Given this list of marker genes PIP4K2C, DNAAF2, ARHGAP35, G3BP2, RAB5A, RSPH1, TBC1D5, STYXL1, KNTC1, EFNB1, DNAH8, INCENP, LSM4, SDC4, VPS37A, UBAP2L, MYH6, SMC3, CDC14C, DNAL1, EHD2, NDUFAF2, TBC1D9B, LMOD2, RPGRIP1L, SNX10, CBLN1, C2CD3, SMC1A, TUBB, ONECUT2, TBC1D12, MEF2A, CRK, CEP126, AP1B1, RAB11FIP3, CEP72, KIF9, TEKT5, SPAG1, VPS4A, RPS15, NOA1, EIF1AX, TPX2, HAP1, SNX4, FLNA, MAPT, SEPTIN7, TBC1D1, CENPC, TRAF6, TUBGCP5, SPEF2 (NCBI Gene Id 80192), B9D1, RAB8B, EIF5B, TCIRG1, VANGL2, DYNC2I2, RAB20, CHMP1B, MYBPC3, BSCL2 (NCBI Gene Id 84753), BBOF1, METTL17, AMBRA1, TMEM216, G3BP1, PWP2, NOP2, TMPRSS12, BCCIP (NCBI Gene Id 56647), STX18, MYO7A, CFAP263, CEP290, UBQLN1, PATL1, KIF23, SPACA9, RCC1L, STAM, MAP4, DDX6 (DEAD-box helicase 6), NME8, CETN1, C1QL2, KIF24, STAM2, NME5, TUBGCP4, CCDC146, LIMK2, GRB7, MTG2, DNMBP, CFAP20, PROX1, ARHGEF5, IFT74, VPS37B, CCDC57, UBXN10, SPAG17, MAP1LC3B, RPSA2, PIKFYVE, CENPW, PLK2, DYNC2I1 (NCBI Gene Id 55112), MYOM3, MRPS2, GBF1, HPS5 (HPS5 biogenesis of lysosomal organelles complex 2 subunit 2), BMP10, CEP44, AUP1, RAB3GAP2, ERAL1, GSN, CFAP65, GABARAP, EHD1, TTLL5 (tubulin tyrosine ligase like 5), POC1B, HYLS1, HGS, IFT43, CFAP74, SMAD4, PPP2R1B, SEC22B (SEC22 homolog B, vesicle trafficking protein), CHMP4BP1, NEGR1, TEKT2, CEP350, UBQLN2 (ubiquilin 2), NUDCD3, IFT140, EVI5, B9D2, DYNC2LI1, CIBAR2, CHMP4A, ATG9B, TMOD2, TBC1D7, PTK2B, TTLL8, DCDC2, MARCHF7, NSFL1C (NSFL1 cofactor), RELN, AVIL, RAB39A (NCBI Gene Id 54734), MYPN, TBC1D21, DAW1, RPF2, MOSPD2, SNX18, B3GLCT, TBC1D17, SPAG6, TMEM237, AAAS, MACIR, RNF4, CFAP57, FUS (FUS RNA binding protein), CCDC13, AP3B1, DNAH17, NUP62, FBXO24, KIF15, MOAP1, CRIPT, NGRN, MTERF4, CDK10, PTPN23, IQCG, CENPX, MPV17L2, DNAI1, SYNPO2L (NCBI Gene Id 79933), TTLL3, AP1S2, MICALL1, DTNBP1, MKKS, C10orf90, TBC1D2, CHN2, VMP1, GABARAPL1, KAT2A, CLN3, CCP110 (NCBI Gene Id 9738), CCNO, EHD4, DYNC1H1, ANKRD23, C1QL3, TNNT3, SDCBP, SPG11 (NCBI Gene Id 80208), ABCC4, ANKRD1, GRID2 (NCBI Gene Id 2895), FAM161A, VTA1, NPM1, GALNT11, CIBAR1, AGFG1, CNOT7, AP1M1, LRRK2, NEK7, CFAP298, CSRP3, SKA1, PSEN1, DCTN1, TIA1 (NCBI Gene Id 7072), TNRC6A, CCDC39, RILPL2, VIPAS39, YTHDF2, ALKBH5, DNAJB13, ACTR2, ATG5, LRFN1, ELMOD1, CENPE, CAPN3, TPGS1, BECN2, DLGAP5, LIMD1, PDGFRB, WWTR1, MAPRE1, KIAA0319L, DZIP1, GMNC, VPS11, MNS1, HAUS7, CCDC159, TXNDC15, CFAP46, CPLANE1, TBC1D24, CENPT, EML3, MAP1LC3B2, CBY1, CEP162, MYBPC1, ARL3, CFAP157, NUMA1, POC5, NBDY, LCP1, SKA2, LRRC46, ACTG1, TBC1D22A, EIF5, GARIN1A, RACGAP1, BIRC5, MZT1, SRPX, MAP10, ARL6, CCDC61, ODAD1 (NCBI Gene Id 93233), CEP63, DNAH1, CORO1A (coronin 1A), DCX, AP1S1, CFAP184, ATG4C, RC3H1, CFAP70, KIFC1, MISP, ONECUT1, RPS5, USP9X, RAB3GAP1, BNIP3, ATAT1, ATXN10, TMEM17, CFAP119, INPP5E, PATL2, WDR35, IFT22, DNAAF1, EVI5L, EDC3, SEPTIN9, ELMOD3, PGM5, FBF1 (Fas binding factor 1), GORAB, GAS8, MYH10, STAG1, BBS7, OCRL, OGFOD1, IQUB, AP5Z1, LRGUK, RAB1A, OBSCN, SMCR8, NPTX1, DEUP1, CSDE1, FLII, RAB14, MYL2, IRGQ, WDR44, EMC6, RPS23, LIAT1, ATG4D, STARD9, CSRP2, SENP6, AURKB, IFT81, ASB2, SEPTIN1, FBXO5, ZFYVE1, NOTO, TMEM175, RAB7A, GDI2, STAG2, RAB33B, DNAH5, STK36, SMURF1, TNP1, CLASP2, MTERF3, DOCK5, IFT172, DCAF17, DRC1, IFT27 (intraflagellar transport 27), IFT56, PRRC2C, DCAF13, KCNJ10, KPNB1, SAXO1 (stabilizer of axonemal microtubules 1), RSPH4A, GFY, TMF1, RIPOR2, NF2, KNL1, NOTCH1, NDC80, RABGAP1, TRAPPC12, WIPI2, TBPL1, TBC1D3, CC2D2B (NCBI Gene Id 414265), SDCCAG8, CFL2, CHMP2A, CDC20B, TMOD3, CFAP91 (cilia and flagella associated protein 91), POGZ, CEP164, BIN2, OFD1, CIRBP, DNAH2 (NCBI Gene Id 57637), KCNQ1 (NCBI Gene Id 3784), VDAC3, PLS1, PIBF1, TBC1D10B, TBC1D10C, CCDC63, FOXJ1, CFAP410, CHMP2B, CROCC, EFL1, DNAAF5, HSF1, ULK3 (NCBI Gene Id 25989), ATG3, CFAP44, HCK, FSCN1, CNOT1, LUZP1, FGFR1, PTEN, CDS1, MVB12A, KCTD17, MPV17L, TP53INP1, TBC1D30, ERICH3, ZMYND10, ARL13A, CCDC15, DNALI1 (dynein axonemal light intermediate chain 1), CCDC38, CEP70, JHY, STX17, KIF4B, MIURF, TCTN3, SBDS (SBDS ribosome maturation factor), MYH11 (NCBI Gene Id 4629), TTC8, SCLT1, TPM1, HPS4, ALMS1, RAB34, UHRF1, ATG12, MYOM1, RSPH6A, AHI1, TNKS, YTHDF3, IFT25, ULK1, TBC1D15, PAFAH1B1, WNK1, EPHB2, CSNK1D, ZPBP2, CFAP221, ATG2B, GABARAPL3, C9orf72, ULK2, ATXN2L, GORASP2, PLK1, CCDC103, CNOT2, HAUS8, ATG4A, FMR1, MAPRE2, ATG16L2, TBC1D31, TRIM37, LRRC61, BCAS2, GSK3B, RPL5, RSPH9, LMOD3, CTSD, PPP2R1A, GARIN3, ODAD2, CDC20 (cell division cycle 20), KASH5, FBXW8, ENKD1, CHMP4C, ZMYND12, VPS13B, RALB, LSM14A, CEP131, CAPRIN1, NRXN1, OBSL1, NRXN2, TTLL1, SPTBN2, UBXN2B, EIF2A, DAZAP2, IFT57, CFAP47, TBC1D14, MYOM2, ATG2A, MKS1, CNOT6L, RCC1, BBIP1, RPS19, RPS14, IFT70B, CDK2, ABLIM3, KIF27, TBC1D8, CPLANE2, DNAAF6, ATMIN (NCBI Gene Id 23300), TNNT2, DNAAF10, BECN1, SCFD1 (sec1 family domain containing 1), TBC1D32, CEP83, CSRP1, RRP7BP, CEP85, CFLAR, TRAPPC14, PRKD1, GK2, CDK5RAP2, SNF8, RAB1C (NCBI Gene Id 441400), TBC1D16, UBAP1, RNF186 (ring finger protein 186), RP1, CHMP1A, DHX30, MFN2, IL1RAP, MTG1, CFAP58, LATS1, RAB19, AP3S1, NEK6, HDAC3 (NCBI Gene Id 8841), CFAP43, AP3S2, FLNC, KRT19, RPGRIP1, DNAI2, SPAG5 (sperm associated antigen 5), ABI3, PIK3C3, ZDHHC12, ABT1, CCNB2, BLOC1S6, MVB12B, RPS27, PIERCE2, CCDC88A, EXOC5, LAMA5, RBM14, NTRK3, ABRAXAS2, ACTR3, CDCA8, E2F4, ELAPOR1, NPHP3, FSIP2, CDS2, KLHL41, CDKL5, NKX2-5, CLASP1, KIF3B, RAB11A, MYOZ1, TBC1D20, TMEM80, RAB32, PLK4, EIF4ENIF1, RHO, DHX29, WNK3, USP6NL, IFT80, CEP192, PRKAR1A, MPHOSPH9, ATP2A2, SH3PXD2B, MLH1, BBS4, HAUS2, PAN2, ACTN2, SOX30, TUBB1, CHMP5, VPS25, CEP19, SDC1, SEPTIN2, GABARAPL2, ACTA1, WDR62, ATG9A, SYNPO, AKT1, DMD, CNOT6, SPICE1, RNF5, PHF23, PLA2G3, TMEM138 (NCBI Gene Id 51524), CLCN4, PISD, MYOZ2, NOP53, KIAA0753, HOATZ, CFAP73, NEB, UBXN2A, TMOD4, DISC1, AURKA, ODF2L, WDR19, ABLIM1, UNC119B, CHMP7, RPL24, RETREG2, MYLK3, CAV3, HPS3, CCDC28B, WRAP73, MYL9, SNX30, YAP1, AURKC, CLXN, STX7, HAUS3, NEBL, SMIM22, TMEM107, STIL (STIL centriolar assembly protein), LSM3, TTN, LZTS2 (NCBI Gene Id 84445), RPSA, RETREG3 (NCBI Gene Id 162427), VIL1, C1QBP, TMEM41B, MCAT, SUGT1, CASKIN1, ABCB6, AR, DNAAF8, TMOD1, CCDC40, HAUS5, SPATA6, CEP97, RAB43, MAPRE3, CENPF, SPAG16, FAM149B1, SPINK2, SLITRK3, FNBP1L, ATG16L1, TNF, SASS6, HSPA1A, FARP2, TCAP, PLEC, MIS12, MDM1, CFAP53, HAUS1, RFX2, CSMD2, PTPRS, KIF11, LRSAM1, KIF4A, CENPA, MRPS7, TAPT1, NRAP, RP1L1, MDN1, RPS27L, VPS37D, PCM1, LPAR1, PSPC1, ALPK1, ATXN2, POLDIP2, CDC14B, FEZ2, BOP1, RNF213, PIP4K2A, DRC7, XRCC5, RRP7A, HPS1, RILP, DUSP23, PCNT, IZUMO3, HDAC6, CEP135, YTHDF1, ACTL7A, CASQ1, SAC3D1, CFAP97D1, FITM1, ATG10, DRG1 (NCBI Gene Id 4733), TRIM32, TBC1D13, IST1, FXR1, VPS33B, ODAD4, HTT, TEKT3, BBS10, MSN, ADAMTS16, MAK, MAPK9, SPEF1, CCDC66, ACRBP, FITM2, FASTKD2, MYBPC2, TOGARAM1, TMEM231, TCTN2, AGO2, P2RX7, MYBL2, EIF6, AKAP13, ACTC1, MTMR3, RABL2B, IFT122, PINK1, RPL10L, CLUAP1, MCIDAS, EHD3, PRKDC, PRC1, DNHD1, NEK1, NUPR1, AP1G1, PKHD1, ATG13, DZIP1L, MIR1-1, TTC12, TSG101, TCTN1, RB1CC1, LRRTM2, PACS2, JMJD6, HYDIN, CCDC69, SQLE (squalene epoxidase), RHOA, VPS28, EZR, WDPCP, BRCA1, ATG101, ATG7, ABCA3 (NCBI Gene Id 21), SPACA1, TP53INP2, MYH3, RAB23, SKA3, GOLGA2, ARHGEF9, AP3M1, CYLC1, RPL11 (ribosomal protein L11), ARL13B (NCBI Gene Id 200894), KCNF1, RUFY4, HNRNPU, WDR90, BBS2, PAN3, CFAP61, CYLD, DDX28, SYT7, NECTIN2, UBE2B, VPS4B, TBC1D10A, SQSTM1, CFAP206, MTOR, LDB3, GAP43, PTPDC1, CILK1, RDX, TTC39C, ATG4B, RETREG1, NTNG2, TBC1D19, PIP4K2B, RAB7B, SYT1, RANGRF, TUBB8, BBS1, SYNE2, RTTN, NEK2, WDR45, TRAF3IP1, CEP295NL, IL5, MYBPH, RPGR, CFAP161, CHMP4B, DNAH7 (NCBI Gene Id 56171), ACTL9, IFT88, RPS3, CSF2, ATG14, GTF2B, ADPRHL1, CCSAP, SNX7, TBC1D22B, CFAP100, INO80, PUM2, CFAP69, MAP1LC3A, WDR45B, WASHC5, RABEP2, NOCT, TUBGCP3, ZNF207, DDX3X, RAB3IP, SRC, WDR11, EHMT2, ARHGEF10, CEP89, IFT52, PPP1R35, TMEM39A, INTU, CEP41, NIP7, RAB8A, TPR, HSPA1B, CENPK, PDCL2 (NCBI Gene Id 132954), CELSR2, ASAP1, RILPL1, ASPM, SSX2IP, RO60, ARF4, PARVA, ANLN, SGSM3, CHMP6, TBC1D2B, PDCD6IP, CEP76, CFAP54, AP1S3, IFT20, LRFN4, STX12, SIX4, GARIN1B, GPSM2, DYNLL1, TTC21B, FAU, DYNC2H1, ATM, TEKT4, MRTO4, POC1A, LRBA, LMOD1 (leiomodin 1), ABRAXAS1, NCOR1, NEURL1, MEIG1, CEP128, DBNL, DNAAF3, ARMC2, SPPL2C, SNAP29, IFT46, CETN2, LSM14B, BICD1, PTPRD, TMEM67, CCDC42, ATP6V1D, CRKL, EIF2S1, DDB1, SLC9A8, LDAF1, PLA2G5, PLN, TNNT1, CAPG, PIERCE1, PRKAA2, PLA2G4C, BAG3, SHANK3, AP3D1, ODAD3, CENPH, VCX, LRRC4B, ZPBP, MAP9, CDKL1, IRGM, CEP20, MTM1, WDR1, DNAAF11, STBD1, MRM2 (NCBI Gene Id 29960), CDC14A, PRICKLE1, CD34, BBS5, KIF3A, ARL8B, KIF2A, DYNLT2B, DNAAF4, CC2D2A, ANG, FHDC1, AP4M1, CCDC65, ENTR1, CHMP3, BBS9, PRKAA1, RP2, ARFIP2, TOM1, WIPI1, FHOD3, EDN1, RFX4, DNAI3, TESK1, MCRS1, ITGB1, HPS6, STING1, VPS36, TEKT1, FUZ, RAB38, RRS1, SH3GLB1, VPS37C, RAB1B, NLGN2, CCDC136, CEP295, HAUS4, LIMA1, USP10, ARMC12, TUBGCP6, AGFG2, IQCB1, CHEK2 (NCBI Gene Id 11200), YIF1B, MARK4, KLC3, RPL38, TUBGCP2, DNAI4, MAPK15, TTBK2, DHX37, CEP152, ODF2, CEP120, ATP6V0D1, ABL1 (ABL proto-oncogene 1, non-receptor tyrosine kinase), CEP250, AKAP4, MFSD14A, WBP2NL, CENPJ, CCDC78, EPM2A, ZAR1, MAP1LC3C, DIAPH3, LRRC23, BRIX1, HAUS6, FEZ1, PDGFRA, TCHP, RPS28 (NCBI Gene Id 6234), WEE2, KAT2B, KIAA0586, RAB33A, RFX3, PFN4, ARMC9, RAB17, CNTROB, SRF, RPS6, here is a description of the gene set: Human Gene Set: GOBP_ORGANELLE_ASSEMBLY species: Homo sapiens The aggregation, arrangement and bonding together of a set of components to form an organelle. An organelle is an organized structure of distinctive morphology and function. Includes the nucleus, mitochondria, plastids, vacuoles, vesicles, ribosomes and the cytoskeleton. Excludes the plasma membrane.